The following is a description of a gene set: species: Mus musculus electronically inferred by orthology from the curated human pathway Reactome Pathway: ZBP1(DAI) mediated induction of type I IFNs This event has been computationally inferred from an event that has been demonstrated in another species.<p>The inference is based on the homology mapping from PANTHER. Briefly, reactions for which all involved PhysicalEntities (in input, output and catalyst) have a mapped orthologue/paralogue (for complexes at least 75% of components must have a mapping) are inferred to the other species. part of: Cytosolic sensors of pathogen-associated DNA , and this is the list of marker genes: Nfkb2, Irf3, Nfkbib, Nfkb1, Nfkbia, Myd88, Rela, Ikbkb, Nkiras1